Given this list of marker genes PIGL, SLC25A24, GNE, NIPBL, UBR1, SMC1A, DLK1, TWIST2, ALG9, ANTXR1, KDM6B (NCBI Gene Id 23135), PIGG, HDAC8, BRD4, CDH11, RTL1, TBX4, WASHC5, CCDC47 (NCBI Gene Id 57003), CHRNG, SMC3, TP63, KRT10, NSD2, FAT4, VPS35L, PTPRF, MEG3, LETM1, TBX3, KMT2D (NCBI Gene Id 8085), CCDC22, RAD21, CPLX1, DPYSL5, IKBKG, PEX2, PORCN, KDM6A, SETBP1, TUBB, WNT3, KIF15, EDA, EDARADD, WNT7A, USP9X, TAF6, RSPO2, EFNB1, MEGF8, PIGN (phosphatidylinositol glycan anchor biosynthesis class N), MGAT2, FIG4, CTBP1, VAC14, NELFA, KCTD1, here is a description of the gene set: species: Homo sapiens Aplasia/Hypoplasia of the nipples Human Gene Set: HP_APLASIA_HYPOPLASIA_OF_THE_NIPPLES